The following is a description of a gene set: Mouse Gene Set: GOBP_POSITIVE_REGULATION_OF_ADIPOSE_TISSUE_DEVELOPMENT Any process that activates or increases the frequency, rate or extent of adipose tissue development. studied in species Mus musculus, and this is the list of marker genes: Mir103-1, Trpm4, Sirt1, Nr1h4, Mir143, Pparg, Sorl1, Mir103-2, Lpl, Sh3pxd2b, Nmnat1, Prkaa1, Ncoa1, Ghrl, Parp1, Ncoa2